Given this list of marker genes SLC40A1, PLAGL2, MVK, TMEM127, EIF5A2, NETO2, LIMA1, ZFYVE9, TUSC2, CENPQ, ATG16L1, AKAP11, RASGEF1A, ENPP5, NAGK, ATAD2 (NCBI Gene Id 84325), STYX, TMEM25, HPS5, CLOCK, KIF5C, PURB, UXS1, DAZAP2, FZD6, FASTK, SIK1, ZBTB5, BTG3, AGO1, CDKN1A, MAPK1, TMEM9B, C9orf40, MAPRE3, RGMA, PKD2, TMEM245, TPRG1L, MFN2, CYBRD1, HIF1AN, FBXL5, ARID4B, JAK1, SFR1, TNFRSF10B, FYCO1, RNH1, NCEH1, ZNFX1, GOLGA1, TLCD3A, RRM2, USP46, NKIRAS1, PRRG1, ELK4, ZNF367, KLF10, TBC1D9, EFCAB14, CFL2, TNFRSF21, TRIM36, GPR137C, TRAPPC14 (trafficking protein particle complex subunit 14), ZBTB6, NUP58, LIMK1, CCND1, TNFAIP1, PRRG4, PUDP, SNX11, CAPRIN2, GPR137B, SLC16A9, AKTIP, MKRN1, CDC37L1, DUSP2, PKIA, CLIP4, PLSCR4, DEDD, RAB22A (NCBI Gene Id 57403), RETREG2, KIAA0513, here is a description of the gene set: from publication Ivanovska I, Ball AS, Diaz RL, Magnus JF, Kibukawa M, Schelter JM, Kobayashi SV, Lim L, Burchard J, Jackson AL, Linsley PS, Cleary MA (PMID 18212054) studied in species Homo sapiens microRNAs in the miR-106b family are overexpressed in multiple tumor types and are correlated with the expression of genes that regulate the cell cycle. Consistent with these observations, miR-106b family gain of function promotes cell cycle progression, whereas loss of function reverses this phenotype. Microarray profiling uncovers multiple targets of the family, including the cyclin-dependent kinase inhibitor p21/CDKN1A. We show that p21 is a direct target of miR-106b and that its silencing plays a key role in miR-106b-induced cell cycle phenotypes. We also show that miR-106b overrides a doxorubicin-induced DNA damage checkpoint. Thus, miR-106b family members contribute to tumor cell proliferation in part by regulating cell cycle progression and by modulating checkpoint functions. A consensus set of genes that were significantly down-regulated by MIR106B. Human Gene Set: IVANOVSKA_MIR106B_TARGETS